Given this list of marker genes MIA2 (NCBI Gene Id 91818), TGFBI, HRG, CLPTM1, SLC52A2, YEATS4, DGKG (diacylglycerol kinase gamma), TMCO3, ELOVL1, WDFY2, SLC23A3, TMEM79, PCP2, ACTL7A, MTHFD2, ACTR2, RAB29, ACSBG2, ZC3H12D, ARF1, PPP4R1, LAMC2, SLC30A3 (solute carrier family 30 member 3), MST1R, CCNF, ATG2A, SYT3, CCDC88B, ST6GALNAC1, UCP2, NMUR2, AGTRAP, HAUS8 (HAUS augmin like complex subunit 8), CLEC1B, SYNJ1, SYK, WDR26, RPS6KA2, SKOR1, MAB21L3, TBPL1, ADORA3, USP39, TRAPPC2, GEMIN7, GREB1L, LMAN2L, PSMD4, ACTG2 (actin gamma 2, smooth muscle), CCNYL1, SMPD5, STK10, TMEM252, TNFRSF1A, PLK1, ITGA3, ACSM2A (acyl-CoA synthetase medium chain family member 2A), ACKR2, FARP1, DGAT2, TLR6, PTPRC, MON1B, AK2, RAP1A, CNKSR2, RABIF, SPIDR, GSDMD, CARHSP1, ARAP3, MYO1H, RBP7, CBLIF, ATG3, ARSB, MCEE, CFAP57, ZNF385B, MYADM, CTBP2, ADAMDEC1, RSPH6A, NHLH1, CITED2, DNAJC4, WAS (WASP actin nucleation promoting factor), PSMA2, CARD6 (caspase recruitment domain family member 6), PRKAR2A, NHERF4, ARHGEF15, GYG1, NEK7, PLEC, SLC23A1, ITPRIPL2, VPS26A, CKB, ELF5, ASTN1, GALNT3, PDLIM5, KBTBD7, PLPP1, AP3S1, EVA1C, GPR108, SUSD6, SLC38A3, TMEM86A, FBXL19, RBM42 (RNA binding motif protein 42), ABI1, SYCP1, ZNF750, PCYT1A, USP15, ENTPD7, UBALD2, TRPC7, BEND6, MARK3 (microtubule affinity regulating kinase 3), KLRK1, COPZ1 (COPI coat complex subunit zeta 1), SPATS2L, NDUFS4, SLC4A1, PRKAB1, MAGI3, STIM2, OXTR, PAGR1, CLIC3, PNPLA7, LMLN, LIMK2, RANBP9 (RAN binding protein 9, NCBI Gene Id 10048), RCHY1, TTLL9, EYA4, IL10RB, CDS2, GFI1, KLRG1, GPR37, TM4SF20, ATG16L2, RBFA, ZNF414, ANKRD12, CFAP119, MBD2, PSMD14, ARHGAP19, ATP6V0D1, KIF14, GPR107, AFF2, OC90, HNRNPLL, ITK, CEP120, ITPR2, ENSA, PRSS37, BANK1, ZBTB8B, TRPV1 (transient receptor potential cation channel subfamily V member 1), KIDINS220, RINL, PRMT9, SLC25A24, HEXB, SLC35G6, HERPUD2 (HERPUD family member 2), PRKCD, PTPN1, MCU, LRRC56, CEACAM20, PIK3CG, PEDS1, ADAMTS18, UBE2F, MED8, TDRD1, PRSS42P, HELZ2, NAIF1, SH3GLB1, ELF4, SHC1, JPH4, BCL2L10, TPPP3 (NCBI Gene Id 51673), ZGLP1, SLC17A6, EIF2AK1, TAX1BP3, here is a description of the gene set: Human Gene Set: GSE27786_LSK_VS_MONO_MAC_DN studied in species Homo sapiens Each fraction of mouse hematopoietic cells was purified by cell sorting from bone marrow of 8-week-old C57BL/6 mice, and its gene expression was analyzed. from publication Konuma T, Nakamura S, Miyagi S, Negishi M, Chiba T, Oguro H, Yuan J, Mochizuki-Kashio M, Ichikawa H, Miyoshi H, Vidal M, Iwama A (PMID 21540074) Genes down-regulated in comparison of LSK versus monocyte macrophages.